Given this list of marker genes ALG6, LZTR1, PMM2, MGAT2, ALG12, MPI, ALG9, SOS1, SLC37A4, NGLY1, ALG8, ALG2, F11, here is a description of the gene set: Decreased activity of coagulation factor XI. Factor XI, also known as plasma thromboplastin antecedent, is a serine proteinase that activates factor IX. Human Gene Set: HP_REDUCED_FACTOR_XI_ACTIVITY studied in species Homo sapiens Reduced factor XI activity